The following is a description of a gene set: studied in species Mus musculus The change in morphology and behavior of a granulocyte resulting from exposure to a cytokine, chemokine, cellular ligand, or soluble factor. Mouse Gene Set: GOBP_GRANULOCYTE_ACTIVATION, and this is the list of marker genes: Spi1, Scnn1b, Tyrobp, Itgam, Fcgr4 (Fc receptor, IgG, low affinity IV), Lypd11, Dnase1l3, Vamp2, Stxbp3, Enpp3 (NCBI Gene Id 432441), Tnf, Il15, Bcr, Ccl3, Prg3, Camp, Ctsg, Ighe, Pikfyve, Traf3ip2, Pi4k2a, Ccr2, Anxa3, Ptafr, Cxcl5, Tex101, Clec12a, Il18rap, Il16, Myd88, Plpp6, Kars1, Ptpn11, Src, Kmt2e, Cd300a, Pram1, Myo1f, F2rl1 (NCBI Gene Id 14063), Pla2g2a, Itgb2l, Syk (spleen tyrosine kinase), Abr, Stx11, Anxa1, Prkcd, Grn, Gkn2, Cd177, Itgb2, Cxcr2, Il18, Dnase1, Fcer1g, Fcer1a, Stx4a, Lypd10, Ccl5, Ptpn6